The following is a description of a gene set: species: Homo sapiens Sle1a.1 is part of the Sle1a lupus susceptibility locus which results in the production of activated and autoreactive CD4+ T cells as well as a reduction in the peripheral regulatory T cell (Treg) pool. Sle1a.1 CD4+ T cells showed a defective response to retinoic acid (RA) expansion of TGFβ-induced Tregs. At the molecular level, Sle1a.1 corresponds to an increased expression of a novel splice isoform of Pbx1, Pbx1-d. Pbx1-d over-expression is sufficient to induce an activated/inflammatory phenotype in Jurkat T cells, and to decrease their apoptotic response to RA. PBX1-d is expressed more frequently in lupus patients than in healthy controls, and its presence correlates with an increased memory T cell population. These findings indicate that Pbx1 is a novel lupus susceptibility gene that regulates T cell activation and tolerance. Genes up-regulated in CD4 T cells: healthy versus systemic lupus erythematosus (SLE). from publication Cuda CM, Li S, Liang S, Yin Y, Potula HH, Xu Z, Sengupta M, Chen Y, Butfiloski E, Baker H, Chang LJ, Dozmorov I, Sobel ES, Morel L (PMID 22180614) Human Gene Set: GSE22313_HEALTHY_VS_SLE_MOUSE_CD4_TCELL_UP, and this is the list of marker genes: IL11, LZTS3, PLCH1, SLC10A3, B3GALT5, SNORA68, ELF4, BMP6, FAM220A, LZTS2, FZD7, PCDHB3, CLN3, UBALD1, PPARG, VSTM4, TNIP1, ABHD5, GRIN3B, CDAN1 (NCBI Gene Id 979), SPNS1, DAG1, CYB5A, NLGN2, AGPAT4, SLC4A3, C1orf220, MAOA, RNF122, MSC, UQCRH, SDC2, FABP4, SMG7, HCAR2, SEPHS2, ALPK2 (NCBI Gene Id 115701), FTH1P5, NFATC2IP, ANKLE2, CLDN1, FAM110B (family with sequence similarity 110 member B), PARP12, TMEM95, RRP1, RPS2P45, OR8H3, CCL18, CC2D1B, ADAMTSL4, FADS3, GPR15LG, RARA, PDXK, SCARNA8, ZFYVE26, ADPGK, TTC39B, MCUR1, TMEM140, PM20D1, SGCE (sarcoglycan epsilon), MMP24, PLIN2, LINC00652 (NCBI Gene Id 29075), OCRL, PIM3, PEX11A, PELI3, RNF24, AP2M1, NUDT16L2P, PITRM1, MTMR11, DIPK2B, CISH, MARCHF9, FAM3A, ADRB3, PECR, ATP6V0A2, OR52M1, SPATS2L, JUND, GSK3A, ECHDC3, WIZ, EIF4A1, GPR12, ZBTB47, TMEM120B, EEFSEC, SEPTIN4, ZNF646 (zinc finger protein 646, NCBI Gene Id 9726), LGALS3, INF2, SHANK3, LYSMD1, G6PD, MFHAS1, CD274, ZNF417, NAGPA, CMTM4, ARRDC1-AS1, SDC4, SEPTIN3, PPP1R15B, ERI1, SPIRE2, FAXC, NCR3, INO80B, SIK2, SMOC1, RRAD, GIT1, PHLDA1, BATF3, RNF227, GAREM2, HCAR3, BAX, TMEM74, PHF24, NUDT16, NPC1, SIRT5, PTPRE, BSX, CYGB, CD44, BAIAP2L2, BCAR3, MIR487A, RNF149, SOCS1, GPR146, WFDC3, RNF157 (ring finger protein 157), ACADVL (NCBI Gene Id 37), SLC26A6, TMEM186, PPP1R14A (protein phosphatase 1 regulatory inhibitor subunit 14A), CENPV (centromere protein V), SLC39A11, JUN, CCDC92, SLC22A5, FAM89A (family with sequence similarity 89 member A), POFUT2, RSPH3, PCYT2, MICALL1, SLC16A5, VLDLR, EMC3, SNX29P2, SLC35E3, SLC6A16, CBS, C7orf50, WFDC1, CHST7, SYT17, UBE2Z, DMRTB1, EFCAB5, MGAT1, KCND2, AICDA, ANKK1, CELP, EBF2, CEBPB, WNT5A, ME3, PSORS1C3, SERINC2, WFS1, MFSD4B, LYRM1, CYTH1, SVIL, FAM86DP, KIR3DX1, KCNE1, PCBD1, AGPAT2, RGL3, PCOLCE2, ABCG2, PLPP3, EFCC1, LRP4, DMBX1, TLE1